Given this list of marker genes FHL1, SUMO3, FOXG1, CTSC, MMP11, FZD6, MMP10 (NCBI Gene Id 4319), FAS, NES, CADM1, GM2A, NDN, MLF1, ACTA2, TNC, TSPAN7, PYHIN1, HOXD8, DCN, CTSZ, TOB1, GPC4, SERPINE2, CD34 (NCBI Gene Id 947), MSX2, PEG3, TNNT2, HOXA1, BTG3, TPD52L1, FOS, TOM1L1, CAVIN2 (caveolae associated protein 2), here is a description of the gene set: Human Gene Set: SCHRAETS_MLL_TARGETS_UP studied in species Mus musculus The human mixed lineage leukemia (MLL) gene is involved in about 50 different chromosomal translocations, associated with the disease phenotype of acute leukemia. However, the normal function of MLL is less understood. Homozygous knockouts of murine Mll were embryonal lethal, while heterozygous disruption led to aberrant hox gene expression associated with skeletal malformations, growth retardation, and impaired hematopoiesis. To understand MLL functions on the molecular level, gene expression profiling experiments were performed with a pair of murine cell lines (MLL(+/+) and MLL(-/-)). Microarray hybridization experiments revealed 197 potential target genes that are differentially expressed, providing new and important clues about MLL functions. Genes up-regulated in fibroblasts from MLL knockout mice. from publication Schraets D, Lehmann T, Dingermann T, Marschalek R (PMID 12789274)